Given this list of marker genes PBX3, TM9SF3, VWC2, GZMK, C5orf63, ZDHHC2, GFI1, ESRRG, NUFIP2, UBN1, NFYC, GRID2, SOX12, SLC5A9, AFG1L, OGT, CDK17, ZNF75D, SLC1A2, ARMC3, ITGBL1, MINPP1, SHB, ARL5B, ZNF268, PUM1, ATRX, MYO7A, PPP6C, PDE1C, ZMYND11, COPG1, PTAR1, POP4, ACAD8, DDX6, ADAM23, GGCX, HTR1F, TTBK2, NDUFS1, DPP10, LRP10, FSD1L (fibronectin type III and SPRY domain containing 1 like), CSRNP3, DDX3X, CDKL1, MACROD2, PCDHA9, CS, FRAS1, CCDC88A, EDEM3, TPH1, STK24, SHOC2, CCNC, CDC37L1, GRIK2, EBF1, PCGF5, SLC25A31, PARVA, SERPINA1, PCDH19, MIS18BP1, SLC30A5, HTRA1, RAP2C, AHCYL2, KDM3A, here is a description of the gene set: Human Gene Set: MIR145_3P species: Homo sapiens from publication Chen Y, Wang X (PMID 31504780) Genes predicted to be targets of miRBase v22 microRNA hsa-miR-145-3p in miRDB v6.0 with MirTarget v4 prediction scores > 80 (high confidence targets).